Given this list of marker genes Cant1, Cd164, Wdr46, Srgap1, Mlf2, Cpsf2, Chd3, Polr1h, Mex3a, Col5a3, Kmt2a, Esrrg, Mief1 (mitochondrial elongation factor 1), Nrxn2 (NCBI Gene Id 320459), AB124611 (cDNA sequence AB124611), Nhsl3, Chtf8, Slc6a8, Slc5a7 (solute carrier family 5 (choline transporter), member 7), Det1, Hipk3, Celf4, Nxph3, Nup155, D16Ertd472e, Itga4, Sprr2a1, Ap3s2, Fign, Mdm4, Rgs8, Snx27, 1700029H14Rik, Usp17la, Nefh, Gnas, Slc26a2, Fcho2 (NCBI Gene Id 218503), Lif, Hsd3b8, Gm10408, Slc22a16, Arl6ip6, Tfcp2l1, C1qtnf1, Plcd4, Zfp936, Mga, Fbln5, Actr3b, Man1c1, Zfp984, Klf12, Ap2m1, Strada, Ctf2, Ttc39b, Pcdhb13, Tmem168, Brca2, Khsrp, Gnpda2, Stat3, Nfat5, Zfp609, Cbx2, Elovl4, Orai2, Hoxb9, Prrc2b, Gripap1, Tox, Kdm2b, Rcc2, A1cf, Mecp2, Csn2, Cfap70, Kdm3b, Slc8a1, Dusp10, Pappa2, Adarb2, Ppp2r2a (protein phosphatase 2, regulatory subunit B, alpha), Grk4, Cd300lg, Nlgn1, Pld5 (NCBI Gene Id 319455), Krtap13-21, Phf8, Pde5a, Gpr146, Pik3cb, Ubqlnl, Sumo1, Atp1b2, Plekhf1, Zc3h7b, Glcci1, Tlr4, Noct, Pea15a, Kcnd1, Ccnh, Appbp2, Sestd1, Sec63, Stim2, Atf7, Sbk3, Prss3b, Dock5, D830030K20Rik, Gprc5b, Prok2, Clic5, Lrig2, Sox14, Strbp, Gss, Bpifa3, Parp9, Ighmbp2, Thrb, Psd, Ube2q2, Ccn3, Pou2f3, Trank1, Hecw1 (NCBI Gene Id 94253), Dedd, Col5a1 (collagen, type V, alpha 1), Lzts3, Gigyf1, Dock3, Osbp2, Mgat4c, Elavl2, Phf12, Map4k2, Tent4a, Sprr2a2, Slco1a6, Mospd2, Chic2, Pappa, Med13, AU018091, Zfp268, Brd8dc, Pkm, Dmgdh, Lce6a, Klrd1, Nectin1, Kat7, Prps1, Snap25, Fjx1, Mtpn, Tshr, Mlph, Pex26, Ar, Aff1, Gm11437, Cap1, Or10d5j, Fgf13, Mapre3, Tbc1d25, Pierce1, Nck2, Cpsf7, Hyou1, Col19a1, Maff, Npas4, Gpr12, Sh3pxd2a, Grm7, Creb3l2, Trim30b, Riok1, Mettl26, Fem1b (fem 1 homolog b), Pla2g4c, Dcaf7, Xpr1, Prps1l3, Hsd3b4, Mpz, Tasor, Fam81a, Dgkk, Ago1, Arcn1, Gtf2e1, Gstm2, Rps6ka6, Hrk, Gls, Cacna1e (NCBI Gene Id 269133), Usp50, Tnrc6b, Atp11c, Mmp14, Lratd1, Rdx, Elp3, Iqgap3, Baiap2, Iws1, Tapt1 (transmembrane anterior posterior transformation 1), Rnf217, Pam, Vps25, Myadm, Hip1, Phex, Rictor, Gas7, Cbl, Arhgef9, Aak1, Ago3, Zfp292, Trim66, Zfp512, Snx15, Napg, Phf2, Klrb1c, Gm826, Ccdc71, Edem2, Arf3, Casp9, Ptbp3, Tmem132e (NCBI Gene Id 270893), Creb5, Larp1, Psd3, here is a description of the gene set: Mouse Gene Set: MIR_7027_5P studied in species Mus musculus Genes predicted to be targets of miRBase v22 microRNA mmu_miR_7027_5p in miRDB v6.0 with MirTarget v4 prediction scores > 80 (high confidence targets). from publication Chen Y, Wang X (PMID 31504780)